Given this list of marker genes Uckl1, Nt5c2, Pnkp, Gm17949, Nme7 (NCBI Gene Id 338485), Clp1 (CLP1, cleavage and polyadenylation factor I subunit), Pck1, Nme2 (NCBI Gene Id 18103), Nme4, Nme5, Cmpk2 (NCBI Gene Id 80594), Pals2, Nmrk1, Dguok, Nme1, Cmpk1, Nme6, N4bp2, Tk2, Guk1, Ak9, Ak6, Ak3, Lrguk, Ak1, Nmrk2, Ak5, Ak7, Ak8, Tk1, Dtymk, Ak4, Uck2, Dck (NCBI Gene Id 13178), Nme3, Ak2, Pals1, Nol9, Uck1, Adk, here is a description of the gene set: studied in species Mus musculus Catalysis of the transfer of a phosphate group, usually from ATP or GTP, to a nucleobase, nucleoside, nucleotide or polynucleotide substrate. Mouse Gene Set: GOMF_NUCLEOBASE_CONTAINING_COMPOUND_KINASE_ACTIVITY